Given this list of marker genes Atp2b4, Atp2a3, Atp2a1, Atp13a4 (ATPase type 13A4), Atp2b2, Atp2c2, Atp2c1, Anxa5, Atp2b1, Atp2b3, Atp2a2, here is a description of the gene set: studied in species Mus musculus Enables the transfer of a solute or solutes from one side of a membrane to the other according to the reaction: ATP + H2O + Ca2+(in) = ADP + phosphate + Ca2+(out). Mouse Gene Set: GOMF_P_TYPE_CALCIUM_TRANSPORTER_ACTIVITY